The following is a description of a gene set: studied in species Mus musculus Mouse Gene Set: GOBP_DENSE_CORE_GRANULE_LOCALIZATION Any process in which a dense core granule is transported to, and/or maintained in, a specific location within the cell., and this is the list of marker genes: Stxbp2, P2rx7, Kif1c, Trim46, Sybu, Mecp2, Cadps, Snap25, Kif1a, Cadps2, Syt4, Rab3a, Tanc2, Syt10, Eipr1, Unc13a, Unc13c, Mapk8, Stxbp1, Kif1b, Ppfia2, Unc13b, Map2, Baiap3, Stxbp3, Kif5a, Kif5b, Syt6, Rims1 (regulating synaptic membrane exocytosis 1), Unc13d